The following is a description of a gene set: Mouse Gene Set: GOCC_EXON_EXON_JUNCTION_COMPLEX species: Mus musculus A multi-subunit complex deposited by the spliceosome upstream of messenger RNA exon-exon junctions. The exon-exon junction complex provides a binding platform for factors involved in mRNA export and nonsense-mediated mRNA decay., and this is the list of marker genes: Srsf1, Eif4a3l1, Casc3, Alyref, Alyreffm11, Pnn, Magohb, Alyreffm8, Alyreffm6, Magoh, Alyreffm5, Sap18b, Alyreffm1, Alyreffm3, Tdrd3, Ccdc9, Pym1, Acin1, Rbm8a, Alyreffm7, Alyreffm9, Alyreffm4, Upf2, Thrap3, Rbm8a2, Upf3b, Sap18, Eif4a3l2, Alyreffm10, Smg6, R3hcc1l, Alyref2, Upf1, Eif4a3